The following is a description of a gene set: The establishment, maintenance and elaboration of the rostro-caudal axis of a somite, prior to the morphological formation of a somite boundary. species: Homo sapiens Human Gene Set: GOBP_SOMITE_ROSTRAL_CAUDAL_AXIS_SPECIFICATION, and this is the list of marker genes: EPB41L5, RIPPLY2, SMAD4, MESP1, TMED2, TBX6, GDF3, LHX1, RIPPLY1, NRARP, MESP2